Given this list of marker genes GPAM, EFNA1, ORMDL3, SLC39A10, KIFAP3, BCL3, TSC22D3, BCL11B, IL2, NOC2L, AURKB, CD27, PDCD1, BMP4, ST3GAL1, PTCRA, HSH2D, ADA, ARG2, FADD, RORC, JAK3, RAG1, BCL6, BCL10, DOCK8, CD74, MIF, CCL5 (C-C motif chemokine ligand 5), PIP, IL7R, BCL2, HIF1A, FOXP1, IRS2, IDO1, SLC46A2, PRKCQ, MIR17HG, here is a description of the gene set: Human Gene Set: GOBP_NEGATIVE_REGULATION_OF_LYMPHOCYTE_APOPTOTIC_PROCESS Any process that stops, prevents, or reduces the frequency, rate or extent of lymphocyte death by apoptotic process. studied in species Homo sapiens